The following is a description of a gene set: Objective: We hypothesized that type 1 diabetes (T1D) is accompanied by changes in gene expression in peripheral blood mononuclear cells (PBMCs) due to dysregulation of adaptive and innate immunity, counterregulatory responses to immune dysregulation, insulin deficiency and hyperglycemia. Research Design and Methods: Microarray analysis was performed on PBMCs from 43 patients with newly diagnosed T1D, 12 patients with newly diagnosed type 2 diabetes (T2D) and 24 healthy controls. One and four month follow-up samples were obtained from 20 of the T1D patients. Results: Microarray analysis identified genes differing in expression between newlydiagnosed T1D patients and controls at a false discovery rate of 0.05. Changes in expression of interleukin-1β (IL1B), early growth response gene 3 (EGR3), and prostaglandin-endoperoxide synthase 2 (PTGS2) resolved within four months of insulin therapy and were also observed in T2D suggesting that they resulted from hyperglycemia. With use of a knowledge base, 81/genes could be placed within a network of interrelated genes with predicted functions including apoptosis and cell proliferation. IL1B and the MYC oncogene were the most highly-connected genes in the network. IL1B was highly overexpressed in both T1D and T2D, whereas MYC was dysregulated only in T1D. Conclusion: T1D and T2D likely share a final common pathway for beta cell dysfunction that includes secretion of interleukin-1β and prostaglandins by immune effector cells, exacerbating existing beta cell dysfunction, and causing further hyperglycemia. The results identify several targets for disease-modifying therapy of diabetes and potential biomarkers for monitoring treatment efficacy. Genes up-regulated in comparison of peripheral blood mononuclear cells (PBMC) from healthy donors versus PBMCs from patients with type 1 diabetes at 1 month after the diagnosis. species: Homo sapiens Human Gene Set: GSE9006_HEALTHY_VS_TYPE_1_DIABETES_PBMC_1MONTH_POST_DX_UP from publication Kaizer EC, Glaser CL, Chaussabel D, Banchereau J, Pascual V, White PC (PMID 17595242), and this is the list of marker genes: NUS1P3, PIK3R1, SNTB2, STX8, RBM39, UQCRC1, NRAS, NKAPD1, SLC35A2, ATP5F1B, TMED2, DAZAP2, ADNP2, TOMM22, PPP1CB, HSPA9, NCBP3, HNRNPA1, CD69, GPAA1, ANP32A, GDI2, DNAJB14, PKN1, NAPG, SIDT1, JUNB, GALNT12, AAMP, DDX3X, RNPS1, UGCG, RBBP4, ASCL2, CANX, PRIM2, FOXK2, EPRS1, ENSA, AHCY, ALDOA, RTN3, HNRNPR, LYPLA1, PABPC4, RAB40B, ACTG1, KPNA5, AATF, BCAP31, HNRNPU, IDS, RNF38, PRKDC, TXNIP (NCBI Gene Id 10628), GPI (glucose-6-phosphate isomerase), MAPK1IP1L, C8orf33, NADSYN1, COPS7B, LRIG2, KPNB1, MATR3, ITGB3, TMEM248, PTP4A2 (protein tyrosine phosphatase 4A2), MKRN1, SLC39A7, HNRNPD, ECSIT, PCNP, ARPC4, OSTF1, XRCC6, SIK1, SOX4, AGPS, PDZK1IP1, SPCS3, SFN, GALNT1, MAP2K1, SUMO3, ZNF394, WDR18, KDELR2, HSP90B1, RBM3, TRAM1, PPP3CB, POTEKP, ACO2, DR1, LAPTM5, ARL6IP1 (NCBI Gene Id 56166), HMGB1, CPNE3, DUSP5, FAM13A, MRPS10, IER5, XAB2 (XPA binding protein 2), COPA, MTHFD1, HNRNPH2, BLK (NCBI Gene Id 84743), TMOD3 (NCBI Gene Id 29766), CSDE1, NPTN, G3BP2, INPP5D, SRSF9, JUN, GSR, H3-4, KLF10, SRRT, MRPL12, ILVBL, STK17B, ZNF551, FLI1, PDIA4, YBX3, KCTD3, CORO1C, TRIM16, PCBP2, HNRNPM, EZR, PAK2, RNF11, ACTR2, NDUFV1, RPN1, STAU1, HNRNPA3, TPST2, FARSA, PSMC3, EIF1AX, MSN, ADAM10, MBD2, CHEK2, PSPN, PSMD2 (proteasome 26S subunit ubiquitin receptor, non-ATPase 2), CLP1, DUSP10, BTBD1, PTBP3, CSNK1G3, EIF3I, HSPA5, EIF4G3, GLUD2, HADHA, SAFB, DPYSL2, MAPRE1, CXCL5, TENT5C, SNX6, PRKAA1, SART1, SFPQ, DNAJA2, ORAI2 (NCBI Gene Id 84917), DDX49, CPSF6, BAG1, TMEM9B, HIF1A, YWHAZ, CYBB, SMARCA2, WTAP, AZIN1, SLC35A3, DDIT4, STT3A, TAP2, NNT, SEC31A, CLN8, URI1, MDM4, SAFB2, ODF2, LSM12, LSM14A, PDIA3, QKI, ATMIN, BNIP2, SYNE2, ANXA5, TOB1 (transducer of ERBB2, 1), BMPR2, GLUD1